Given this list of marker genes Casp2, Cradd, here is a description of the gene set: This event has been computationally inferred from an event that has been demonstrated in another species.<p>The inference is based on the homology mapping from PANTHER. Briefly, reactions for which all involved PhysicalEntities (in input, output and catalyst) have a mapped orthologue/paralogue (for complexes at least 75% of components must have a mapping) are inferred to the other species. part of: TP53 Regulates Transcription of Cell Death Genes Reactome Pathway: TP53 Regulates Transcription of Caspase Activators and Caspases electronically inferred by orthology from the curated human pathway species: Mus musculus